The following is a description of a gene set: studied in species Homo sapiens Any process that stops, prevents or reduces the frequency, rate or extent of reactive oxygen species metabolic process. Human Gene Set: GOBP_NEGATIVE_REGULATION_OF_REACTIVE_OXYGEN_SPECIES_METABOLIC_PROCESS, and this is the list of marker genes: PRKN, PINK1, NDUFC2, ABCD1, ADCY10, PARK7, MIR181A2, VDAC1, TP53, INS, TIGAR, ABCB7, PON3, PAX2, MIR590, PLIN5, SIRT5, PAGE4, MT3, HDAC6, SIRT3, ACP5, RHOA, HK2, MIR675, HP, ABCD2, FYN, MIR21, TFAP2A, STAT3, BCR, BRCA1, SLC18A2, MPV17L, CRYAB, MMP3, G6PD, SIRT2, MYCN, CFLAR, PPARA, TRAP1